The following is a description of a gene set: studied in species Mus musculus Any signaling pathway that increases or activates a cell cycle cyclin-dependent protein kinase to modulate the switch from G1 phase to S phase of the mitotic cell cycle. Mouse Gene Set: GOBP_POSITIVE_REGULATION_OF_G1_S_TRANSITION_OF_MITOTIC_CELL_CYCLE, and this is the list of marker genes: D1Pas1, Plrg1, Anp32b, Ddx3x, Rpl17, Tfdp1, Hyal1, Apex1, Ccne1, Akt1, Crebbp, Adam17, Mtbp, Ccnd2, Rptor, Anxa1, Aif1 (allograft inflammatory factor 1), Cpsf3, Ube2e2, Egfr (epidermal growth factor receptor), Ccne2, Rrm1, Stil (Scl/Tal1 interrupting locus), Cyp1a1, Ccnd3, Larp7, Ddr2, Adamts1, Mepce, Cul4b, Ccnd1, Stox1, Lsm10 (U7 snRNP-specific Sm-like protein LSM10), Cul4a, Cenpj, Sass6, Fgf10, Dbf4, Tert, Plcb1, Mdm2, Rdx, Ankrd17, Lsm11, Rrm2, Kmt2e, Rgcc, Mblac1, Eif4g1, Kcna5 (NCBI Gene Id 213586)